The following is a description of a gene set: The chemical reactions and pathways involving lactate, the anion of lactic acid. species: Homo sapiens Human Gene Set: GOBP_LACTATE_METABOLIC_PROCESS, and this is the list of marker genes: TP53, MRS2, MTCH2, LDHD, TIGAR, LDHAL6A, HAGH, LDHC, PNKD, PFKFB2, PARK7, PER2, HIF1A (hypoxia inducible factor 1 subunit alpha), MIR210, LDHAL6B, D2HGDH, LDHA, LDHB, GATD1, ACTN3